The following is a description of a gene set: Reactome Pathway: Activated NTRK2 signals through FYN This event has been computationally inferred from an event that has been demonstrated in another species.<p>The inference is based on the homology mapping from PANTHER. Briefly, reactions for which all involved PhysicalEntities (in input, output and catalyst) have a mapped orthologue/paralogue (for complexes at least 75% of components must have a mapping) are inferred to the other species. part of: Signaling by NTRK2 (TRKB) species: Mus musculus electronically inferred by orthology from the curated human pathway, and this is the list of marker genes: Fyn, Bdnf